The following is a description of a gene set: species: Mus musculus Mouse Gene Set: GOBP_GROWTH_HORMONE_RECEPTOR_SIGNALING_PATHWAY_VIA_JAK_STAT The process in which STAT proteins (Signal Transducers and Activators of Transcription) are activated by members of the JAK (janus activated kinase) family of tyrosine kinases, following the binding of physiological ligands to the growth hormone receptor. Once activated, STATs dimerize and translocate to the nucleus and modulate the expression of target genes., and this is the list of marker genes: Tyk2 (tyrosine kinase 2), Stat5a, Stat5b (signal transducer and activator of transcription 5B), Jak3, Jak2, Jak1, Stat6, Ghr, Stat3